The following is a description of a gene set: An abnormal elevation of phytanic acid. species: Homo sapiens Human Gene Set: HP_ELEVATED_CIRCULATING_PHYTANIC_ACID_CONCENTRATION Elevated circulating phytanic acid concentration, and this is the list of marker genes: PEX6, PEX19, PEX5, PEX14, PEX3, PEX11B, PEX10, PEX12, PEX7, PEX13, PEX1, PEX2, PEX16 (peroxisomal biogenesis factor 16), PEX26, PHYH, AMACR